The following is a description of a gene set: studied in species Mus musculus A SWI/SNF-type complex that is found in neural stem or progenitor cells, and in human contains actin and proteins encoded by the ARID1A/BAF250A or ARID1B/BAF250B, SMARCD1/BAF60A, SMARCD3/BAF60C, SMARCA2/BRM/BAF190B, SMARCA4/BRG1/BAF190A, SMARCB1/BAF47, SMARCC1/BAF155, SMARCE1/BAF57, SMARCC2/BAF170, PHF10/BAF45A, ACTL6A/BAF53A genes. The npBAF complex is essential for the self-renewal/proliferative capacity of the multipotent neural stem cells. Mouse Gene Set: GOCC_NPBAF_COMPLEX, and this is the list of marker genes: Smarcd3, Smarcd1, Ss18, Arid1a (NCBI Gene Id 93760), Actl6a, Smarcc2, Smarca4, Actb, Smarce1, Smarcb1, Smarcc1, Smarca2, Phf10